Given this list of marker genes GABRG1, GABRA3, GABRA4, GABRA1, GABRB2, GABRB3, GABBR1, GABRE, GABRP, GABRR3, GABRR2, GABRA5, GABBR2, GABRQ, GABRG2, GABRB1, GABRR1, GABRD, GABRG3, GABRA2, GABRA6, here is a description of the gene set: Human Gene Set: GOCC_GABA_RECEPTOR_COMPLEX studied in species Homo sapiens A protein complex which is capable of GABA receptor activity. Upon binding of gamma-aminobutyric acid (GABA) it transmits the signal from one side of the membrane to the other to initiate a change in cell activity. Major inhibitory receptor in vertebrate brain. Also found in other vertebrate tissues, invertebrates and possibly in plants. Effective benzodiazepine receptor.